The following is a description of a gene set: Abnormality of hair texture species: Homo sapiens Human Gene Set: HP_ABNORMALITY_OF_HAIR_TEXTURE An abnormality of the texture of the hair., and this is the list of marker genes: EPS8L3, KRT83, NSUN2, SMAD4, SUZ12, NECTIN1, WDR35, RRAS, RAF1, CARS1, CTC1, H4C5, HRURF, TRMT10A, TGM3, NAA10, CDSN, ALX4, MED12, C18orf32, DYM, CCDC47, GNPTAB, ERCC2, TCHH, CBS, HECTD4, PADI3, KRT1, PUM1, PTPN11, OFD1, SPRED2, KRT85, KRT86, AHCY, GNB2, VPS33A, FLNA, LZTR1 (NCBI Gene Id 8216), TWIST2, ALMS1, SON (NCBI Gene Id 84155), COL3A1, BCKDK, ARID1B, TNFSF11, SOS1, DCAF17, GTF2E2, WBP4, TRPS1, RPL21, PPP1R13L, CBL, KRT81, RASA2, PTEN, DSG4, IFT43, BRAF, SOS2, EBP, SLC7A7, PPP1CB, LIPH, MTOR, SEC23A, SUMF1, TP63, GON7, TUFT1, TRIM8, ATAD3A, ERCC8, TRNT1, SCUBE3, SMARCAL1, PCNT, HRAS, ST14, PPP1R15B, DSC2, TINF2, KRAS, LPAR6 (NCBI Gene Id 10161), ABCD1 (ATP binding cassette subfamily D member 1), NOTCH2, SIN3A, SVBP, SMARCA2, KCTD1, MRAS, TCIRG1, CDH3, RRAS2, DSG2, PQBP1, ATP7A, SKIC2, RPS23, NECTIN4, EFNB1, ERCC3, IKBKG, RNF113A, AARS1 (NCBI Gene Id 16), KANK2 (NCBI Gene Id 55598), MAP2K1, BCS1L, DPYSL5, JUP, PHGDH, KANSL1, PIGL, MSX1, MPLKIP, TMCO1 (NCBI Gene Id 54499), WNT10A, PORCN, EDA, GJB6, RMRP, ASL, NSD1, CLCN7, PYCR1, RNU4ATAC, PLOD3, HNRNPH2, EDARADD, SKIC3, ATP6V1A, HGSNAT, NOTCH3, SLC25A24, PRR12, HR, SPINK5, HEATR3, GNS, ZFX, BRF1, CDK13, SREBF1, CSTB, RLIM, GUSB, CERT1, EZH2, TMEM147, GATAD2B (GATA zinc finger domain containing 2B), CHD6, KRT17, DEAF1, AFF4, RIPK4, SHOC2, TARS1, GTPBP2, MPV17, OCRL, KREMEN1, NRAS, SNX10, USP9X, DSP, ERCC6, PERP, KRT25, HPD, NAGLU, NFIX, TTC5, RIT1, SGSH, SATB2, IFT122, ATP6V1E1, RPS6KA3, ATP6V0A2, KRT71, GTF2H5, MAP2K2, LIG4, FOCAD, KRT74 (NCBI Gene Id 121391), ZMPSTE24, EDAR, SUOX, NBAS, KAT6B, GAN, ITGA3, SIN3B, GJA1